The following is a description of a gene set: The alteration of the C-terminal amino acid residue in a protein. Human Gene Set: GOBP_C_TERMINAL_PROTEIN_AMINO_ACID_MODIFICATION species: Homo sapiens, and this is the list of marker genes: LCMT1, AGBL5, AGBL1, FOLH1B, AGBL4, ATG16L1, FOLH1, ICMT, AGTPBP1, IRGM